Given this list of marker genes PSMD14, PSMB6, PSMD8, ADRM1, PSMA8, PSMC4, PSMD6, PSMD2, PSMA2, PSMB2 (NCBI Gene Id 5690), PSMB3, PSMD7, PRNP, SEM1, PSMB5, PSMA4, PSMC2, PSMA7, PSMB7, PSMD13, PSMD12, PSMD11, PSMB1, PSMD4, PSMA1, PSMA5, PSMC5, PSMC1, PSMC3, PSMA3, PSMD1, PSMB4, PSMD3, PSMC6, PSMD9, PSMA6, here is a description of the gene set: Scrapie conformation PrPSc to 26S proteasome-mediated protein degradation. Pathway ID: N01197. Pathway type: Variant. Pathway class: nt06465 Prion disease. Pathway Definition from KEGG: PRNP* -| 26S Human Gene Set: KEGG_MEDICUS_VARIANT_SCRAPIE_CONFORMATION_PRPSC_TO_26S_PROTEASOME_MEDIATED_PROTEIN_DEGRADATION studied in species Homo sapiens